The following is a description of a gene set: In this study we compared the effects of IL-2, IL-15, and IL-21 on the gene expression, activation of cell signaling pathways, and functional properties of cells derived from the CD4+ cutaneous T-cell lymphoma (CTCL). Whereas both IL-2 and IL-15 that signal through receptors that share the common gamma chain and the beta chain modulated the expression of >genes, IL-21 that signals via the receptor also containing gamma chain up-regulated <genes. All three cytokines induced tyrosine phosphorylation of Jak1 and Jak3. However, only IL-2 and IL-15 strongly activated STAT5, PI3K/Akt, and MEK/ERK signaling pathways. In contrast, IL-21 selectively activated STAT3. Whereas all three cytokines protected CTCL cells from apoptosis, only IL-2 and IL-15 promoted their proliferation. The effects of the cytokine stimulation were Jak3- and Jak1-kinase dependent. These findings document the vastly different impact of IL-2 and IL-15 vs. IL-21 on malignant CD4+ T cells. They also suggest two novel therapeutic approaches to CTCL and, possibly, other CD4+ T cell lymphomas: inhibition of the Jak1/Jak3 kinase complex and, given the known strong immunostimulatory properties of IL-21 on CD8+ T, NK, and B cells, application of this cytokine to boost an immune response against malignant CD4+ T cells. Human Gene Set: GSE8685_IL2_STARVED_VS_IL15_ACT_IL2_STARVED_CD4_TCELL_UP species: Homo sapiens Genes up-regulated in Sez-2 cells (T cell lymphoma): untreated versus IL5. from publication Marzec M, Halasa K, Kasprzycka M, Wysocka M, Liu X, Tobias JW, Baldwin D, Zhang Q, Odum N, Rook AH, Wasik MA (PMID 18281483), and this is the list of marker genes: CEPT1, MTMR3, TBRG1, EXOC5, RRP7A, BRDT (bromodomain testis associated), WDR91, NSD3, IFIT1, PRKCA, BRI3BP, FAM241A, MNAT1, MALAT1, INTS6L, RPS15A, SMC4, ATRAID, RRAGA, MPHOSPH10, RRP36, HMGN3, LINC00511, CKB, GRB10, TMEM176B, MATK, TBXA2R, QNG1 (NCBI Gene Id 84267), ATP6V1B2, FOXN3, C9orf78, HTATIP2 (HIV-1 Tat interactive protein 2), CACYBP, MSMO1, IFIT2, SETDB1, TAF5L, RIMOC1, FEZ2, FBXO38, GPR35, TNFRSF4, TRMU, ADSL, TOR1AIP2, IFIH1, NSMCE3, NPRL2, PPM1L, TMX4, PLPP1, PAICS, CTNNBL1, TIMM23, JAK1, FAAH, FTSJ3, C14orf119, DOCK10 (NCBI Gene Id 9714), MIIP, PANK4, TOMM40L, ABITRAM, ZEB1, RBIS, DNAJA1, FNBP4, CNIH1, SEC24B, SAA2, SERPINI1, GAPVD1, NEDD4L, PIK3CD, ZMYND8, SDC3, SEL1L, NRROS (NCBI Gene Id 375387), CNST, DNTT, IRF9, PKM, DLG1, HOXA5, AGO1, DPP4, DDX50, FBXL3, FBF1, ACSL3, SLC26A10P, ARV1, TECPR1 (tectonin beta-propeller repeat containing 1), HMGCR, PTHLH, DCC, STAP1, OAT, TMPRSS15, TSNAX, SPATA6, NUDT6, CRBN, PPP1R15A, PXK, GATA3, FAM50A, PSME1, MRM1, C8orf33, IRF6, KANSL1, CBX8, ACADVL, TGIF2, PAQR8, SLC2A5, QTRT1 (NCBI Gene Id 81890), CLTB, HIGD2A, TAX1BP1, UBXN4, BARHL2, NPM3, CLEC4G, FAM53A, THUMPD3, DLG3, NEK7, ADI1, ECEL1, C19orf53, CFAP69, DNAJB13, BST2, COPG1, CD8B, CAPG (NCBI Gene Id 822), TUBA4A, BCL2A1, NFE2L2, ESD, TMBIM4, COG6, SATB1, PFN1, DCUN1D2, TMEM179B, TMEM63A, PDYN, CLPTM1, PCBP2, BDH1, SP3, KAT2B, PLRG1, RAP1B, FGF3, CLCN4, CHMP2A, ZC3H7A, RPLP2, TAF4B, PRPF38A, PROX2, FAM181B, PFDN4 (NCBI Gene Id 5203), CHIC2, ADD3, AIP, SAR1A, DAXX, UTRN, ZNF623, ADGRA1, LENG1, CHID1, FBXO6, ATF7IP, UCP3, ESCO1, RAB5IF, POLR3C, ZBTB43, DHRS1 (NCBI Gene Id 115817), GUCD1, HVCN1, RNF19A (ring finger protein 19A, RBR E3 ubiquitin protein ligase), CIB3, UBE2W, ZDHHC4, NXF1, PHPT1, EPC1, YRDC (yrdC N6-threonylcarbamoyltransferase domain containing), GOLGA7, TMEM38B, COX14